Given this list of marker genes SLC25A14, UCP3, SLC25A27, UCP2, UCP1, here is a description of the gene set: The "fatty acid cycling" hypothesis proposes that protonated fatty acids flip-flop in the membrane and deliver a proton to the matrix side. UCP1 catalyses the return of the fatty acid anion to the cytosolic side of the membrane, resulting in net proton transport catalysed by the protein. species: Homo sapiens Reactome Pathway: The fatty acid cycling model part of: Mitochondrial Uncoupling